The following is a description of a gene set: studied in species Mus musculus Mouse Gene Set: GOBP_NEGATIVE_REGULATION_OF_GLYCOPROTEIN_METABOLIC_PROCESS Any process that stops, prevents or reduces the frequency, rate or extent of glycoprotein metabolic process., and this is the list of marker genes: Itm2b, Itm2a, Jak3, Hbegf (NCBI Gene Id 225370), Abca7, Itm2c, Slc2a10, Oga, Bace2, Ptx3, Acot8, Apcs, Mgat4d, Aatf, Ago2, Cst3